Given this list of marker genes Gm6483, Gm13034, Secisbp2, Mid1, Bptf, Dpm1, Klhl42, Notum, Eef1e1, Hsp90ab1, Lrrn4 (NCBI Gene Id 320974), Rad23a, Dbn1, St8sia1 (NCBI Gene Id 320852), Sgce, Dhx32, Ngef (NCBI Gene Id 53972), Rrp9, Hip1r, Anapc5 (anaphase-promoting complex subunit 5), Mxi1, Tsr1, Polrmt, Mir7079, Cep76, Dnah14, Akip1, Gm15564, Esp8, Ebag9, Gm13135, Tsfm (Ts translation elongation factor, mitochondrial), Duxf1 (double homeobox family member 1), Tmem267, 3110070M22Rik, Aip, Abcf1, Itpa-ps2, Smarcb1, Pygm, Zfp1006, Kif19b, Gm11399, Rpl27, Gpc2, Dynlt1a, Tmc4, Tet2, Gm11400, Cebpb, Pgam5, 1700112K13Rik, Bicra, Scarf2 (scavenger receptor class F, member 2), Cacybp, Yars1, Gm13140, Smarca5, Msh4, Gm12366, Hnrnph1, Nup43, Mir7236, Ppil4, Coil, Mmut, Agpat1, Speer4cos, Radil, Gm8357, Nr2f6, Nudc (NCBI Gene Id 18221), Mir466i, Rbm6, Rraga, Tpd52, Sfi1, Lin52, Rrbp1, Mrpl48, Dynlt1b, Cacnb1, Marchf9, Gm22863, Kcnh7, Rimbp2, Pomp, Tbc1d1, Gm13170, Hnf1aos1, Serinc5, Cabp1, Ccdc39, Abcg2 (ATP binding cassette subfamily G member 2 (Junior blood group)), Btnl10, Cdc42, Podn, Cited4, Rsbn1l, Exoc6, Gm14401, Podnl1, Septin4, here is a description of the gene set: from publication Yevshin I, Sharipov R, Kolmykov S, Kondrakhin Y, Kolpakov F (PMID 30445619) Genes containing one or more binding sites for (Ubn1) in their promoter regions (TSS -1000,+100 bp) as identified by GTRD version 20.06 ChIP-seq harmonization. studied in species Mus musculus Mouse Gene Set: UBN1_TARGET_GENES